The following is a description of a gene set: An abnormality of the intrahepatic bile duct. Abnormal intrahepatic bile duct morphology Human Gene Set: HP_ABNORMAL_INTRAHEPATIC_BILE_DUCT_MORPHOLOGY studied in species Homo sapiens, and this is the list of marker genes: PEX14, IL12RB1, PKHD1, MMEL1, IRF5, CC2D2A, IL12A, TCTN3, MED12, ZFYVE19, RPGRIP1L, LMNA, PEX5, INPP5E, JAG1, TNFSF15, LMBRD1, SPIB, KIF3B, DZIP1L, CLDN1, PEX1, IFT56, POU2AF1, TNPO3, VPS33B, TMEM67, DCDC2, PEX2 (NCBI Gene Id 5828), AKR1D1, WDR19